The following is a description of a gene set: species: Homo sapiens Covalent attachment of a glycosyl residue to a lipid molecule. Human Gene Set: GOBP_LIPID_GLYCOSYLATION, and this is the list of marker genes: GBGT1, GBA2, A3GALT2, B4GALNT1, ST3GAL2, ABO, ST3GAL4, B3GALT1, SLC35C1, GBA1, B4GALNT2, GLT6D1